The following is a description of a gene set: species: Homo sapiens Human Gene Set: GOCC_PORE_COMPLEX A protein complex providing a discrete opening in a membrane that allows the passage of gases and/or liquids., and this is the list of marker genes: C8B, ADAM10, AFDN, SLC25A5, VDAC2, C9 (complement component 9), SLC25A31, BAK1, PLEKHA7, CD34, SLC25A4 (NCBI Gene Id 7872), C8G, C5, SPG7, BAX, TOMM40L, TSPAN33, C6, PDZD11, C7, BCL2, C8A, VDAC1, PPIF, VDAC3, TOMM40